The following is a description of a gene set: Mouse Gene Set: GOMF_BOX_H_ACA_SNORNA_BINDING Binding to a box H/ACA small nucleolar RNA. species: Mus musculus, and this is the list of marker genes: Dkc1, Nhp2, Nop10, Nolc1, Gar1